Given this list of marker genes Igf1, Igfbp6, Igfbp3, Igfals, Igfbp5, here is a description of the gene set: studied in species Mus musculus Mouse Gene Set: GOCC_INSULIN_LIKE_GROWTH_FACTOR_BINDING_PROTEIN_COMPLEX A complex of proteins which includes the insulin-like growth factor (IGF) and a number of IGF-binding proteins. The complex plays a role in growth and development.